The following is a description of a gene set: Mouse Gene Set: GOBP_POSITIVE_REGULATION_OF_SKELETAL_MUSCLE_CELL_PROLIFERATION Any process that activates or increases the frequency, rate or extent of skeletal muscle cell proliferation. species: Mus musculus, and this is the list of marker genes: Stat3, Selenon (NCBI Gene Id 74777), Jak2, Shh, Sirt1